The following is a description of a gene set: An increased susceptibility to pharyngitis as manifested by a history of recurrent pharyngitis. Recurrent pharyngitis Human Gene Set: HP_RECURRENT_PHARYNGITIS species: Homo sapiens, and this is the list of marker genes: P4HA2, HLA-DRB1, XIAP, TNFRSF1A, PTPN22, HLA-B, SH2D1A, ALG12, SLC29A3, NFKB2